The following is a description of a gene set: Human Gene Set: GSE22886_NAIVE_TCELL_VS_DC_DN species: Homo sapiens from publication Abbas AR, Baldwin D, Ma Y, Ouyang W, Gurney A, Martin F, Fong S, van Lookeren Campagne M, Godowski P, Williams PM, Chan AC, Clark HF (PMID 15789058) Genes down-regulated in comparison of naive CD4 CD8 T cells versus unstimulated dendritic cells (DC). Immune cell-specific expression is one indication of the importance of a gene's role in the immune response. In order to identify such patterns, we set out to broadly profile gene expression in a variety of immune cells., and this is the list of marker genes: CREG1, PLBD1, NRP1, RAB32, RAB13, ADA2, NRGN, GLB1, SNX1, LY96, F13A1, SPG21, DEGS1, CCDC47, SNX13, FCER2, FES, ASAP1, SYNJ1, TREM2, MFSD1, NR4A3, CSTB, RPE, E2F6, PSMB5, COX8A, KCTD5, MREG, LAMTOR2, RNH1, ARPC5, ZNF185, SQSTM1, HSPA4, DSE, FLVCR2, ABHD6, CD36, MGST2, NQO1, NEU1 (NCBI Gene Id 4758), KYNU, SLCO2B1, KCTD12, NFE2L2, TM9SF2, FTL, PTGS1, SLC6A6, PLAU, RBM47, KIAA0930, CTNNA1, GAA, M6PR, PI4K2A, GCA, WDFY3, RIT1 (NCBI Gene Id 6016), PCBD1, ZNF267, MAP1S, PPP1R10 (protein phosphatase 1 regulatory subunit 10), SLC31A2, MFN2, PIR, ZNF804A, AP3B1, CYP51A1, GRAMD4, DOK1, PGD, BCKDK, EHD4, SDCBP, ATP6V0B, VAMP3, TBC1D12, DHCR24, STAB1, ADAP2, QPCT, SNX3, GLRX2, EPAS1, MPV17, SDC2, HGSNAT, ATP6V1E1, SLC7A8, SLC48A1, MAN2B1, ENTPD1, LAMP2, GPR137B, STAC, SMCO4, RAMP1, EPB41L3, CORO1C, NFE2L1, SYK, PLA2G7, SLC27A3, LRP12, SLAMF8 (NCBI Gene Id 56833), VIM, STAM2, PSMD1, PEA15, TOP1, CTNS, NCSTN, ADAM17, TALDO1, ATP6V1F, ATG7, MARCHF1, CCDC88A, ACO2, ALDH2, SPINT1, MACROH2A1, CAPRIN1, SUOX, TPI1, PLEKHB2, VDAC1, MAOA, RAC1, SYNGR2, ST14, DAPK1, C1QA, MTMR14, GLA, KMO, IGSF6, ITFG1, BCAR3, TXNRD1, CAMK1, STK3, FEZ2, BLVRB, MITF, ZMIZ1, ANPEP, CTSZ, NDUFV2, LIPA, KCNJ2, DEF8, PLIN3, PTPRE, GABARAP, ATP8B4, CYB5R4, PREP, FPGT, PSEN2, DAB2, RAB7A, RCOR1, PPP1R3D, PRDX1, TFG, NCF4, SLC16A6, CRIM1, SIRPA, GPX1, HLA-DMB, RCBTB2, TIGAR, HSBP1, HLA-DMA, TPM4, DOCK4, LARP4, IFNGR1, VASH1 (vasohibin 1), GRK3, TST, ZFYVE21, PPIF, NAGA, RNASE6, CEBPA, ZFYVE26, GCLC, MTHFD2, LHFPL2, ATP1B1, HOMER2, LAPTM4A, PPT1, CDK5, MDH1